Given this list of marker genes LKAAEAR1, TCEAL5, CDH2, ENO1, ISYNA1, NUCB2, SPINK2, SMIM24, CPXM1, CDK6-AS1, FLT3, CDK6, TM7SF3, FAM216A, AIF1L, ARMH1, CLDN10, CLGN, DNAJC12, BZW2, here is a description of the gene set: species: Homo sapiens from publication Hay SB, Ferchen K, Chetal K, Grimes HL, Salomonis N (PMID 30243574) Human Gene Set: HAY_BONE_MARROW_CD34_POS_MULTILIN